Given this list of marker genes SIAH1, LMBRD1, SDK2, PLPP3, APLP2, TMEM243, SH3BGRL2, PTPRN2, ORMDL3, PDK2, RMST, here is a description of the gene set: Undifferentiated and poorly differentiated thyroid tumors are responsible for more than half of thyroid cancer patient deaths in spite of their low incidence. Conventional treatments do not obtain substantial benefits, and the lack of alternative approaches limits patient survival. Additionally, the absence of prognostic markers for well-differentiated tumors complicates patient-specific treatments and favors the progression of recurrent forms. In order to recognize the molecular basis involved in tumor dedifferentiation and identify potential markers for thyroid cancer prognosis prediction, we analysed the expression profile of 44 thyroid primary tumors with different degrees of dedifferentiation and aggressiveness using cDNA microarrays. Transcriptome comparison of dedifferentiated and well-differentiated thyroid tumors identified genes with >2-fold difference in absolute values and false discovery rate of <0.15. According to known molecular interaction and reaction networks, the products of these genes were mainly clustered in the MAPkinase signaling pathway, the TGF-beta signaling pathway, focal adhesion and cell motility, activation of actin polymerization and cell cycle. An exhaustive search in several databases allowed us to identify various members of the matrix metalloproteinase, melanoma antigen A and collagen gene families within the upregulated gene set. We also identified a prognosis classifier comprising just 30 transcripts with an overall accuracy of 95%. These findings may clarify the molecular mechanisms involved in thyroid tumor dedifferentiation and provide a potential prognosis predictor as well as targets for new therapies. species: Homo sapiens from publication Montero-Conde C, Martín-Campos JM, Lerma E, Gimenez G, Martínez-Guitarte JL, Combalía N, Montaner D, Matías-Guiu X, Dopazo J, de Leiva A, Robledo M, Mauricio D (PMID 17873908) Human Gene Set: MONTERO_THYROID_CANCER_POOR_SURVIVAL_DN Down-regulated genes predicting poor survival of patients with thyroid carcinoma.